The following is a description of a gene set: from publication Chen X, Barozzi I, Termanini A, Prosperini E, Recchiuti A, Dalli J, Mietton F, Matteoli G, Hiebert S, Natoli G (PMID 22802645) Human Gene Set: GSE33162_HDAC3_KO_VS_HDAC3_KO_MACROPHAGE_DN Genes down-regulated in macrophages with knockout of HDAC3: heterozygous versus homozygous. Pan-Hdac inhibitors (HDACi) are endowed with a potent anti-inflammatory activity, but the relative role of each of the eleven Hdac proteins sensitive to HDACi to the inflammatory gene expression program is unknown. Using an integrated genomic approach we found that Hdac3-deficient macrophages are unable to activate almost half of the inflammatory gene expression program when stimulated with lipopolysaccharide (LPS). A large part of the activation defect is due to loss of basal and LPS-inducible expression of IFNb, which in basal cells maintains Stat1 protein levels, and after stimulation acts in an autocrine/paracrine manner to promote a secondary wave of Stat1-dependent gene expression. We show that loss of Hdac3-mediated repression of nuclear receptors leads to hyperacetylation of thousands of genomic sites and associated gene derepression. The upregulation of the constitutively expressed prostaglandin endoperoxide synthase, Ptgs1 (Cox-1), has a causative role in the phenotype, since its chemical inhibition reverts the Ifnb activation defect. These data may have relevance for the use of selective Hdac inhibitors as anti-inflammatory agents. studied in species Homo sapiens, and this is the list of marker genes: RTRAF, SELENOT, PVT1, LAMTOR1, TSPAN31, ANXA2, VPS13C, ACTG2 (NCBI Gene Id 72), PLP2, PRPF39, SORL1, RUNX2, RIOK3, ADGRG3, DSTN, COMMD2, VMP1, LIG3, ENTPD4, SLC66A3, TRAM1, ST3GAL6, KLF6, SDCBP, MICOS10, GGH, PTGR3, RABGEF1, MAST2, PGK1, RWDD1 (NCBI Gene Id 82733), UGGT2, ADAM19 (ADAM metallopeptidase domain 19), SEMA4B, KLHDC2, CAB39, EOMES, ANP32B, S100A6, ZFP36L2, THTPA, PRDX4, MDFIC, WTAP, SERPINB6, PUS10, USP3, S100A4, TCF19, IER3, SH3GLB1, KIF4A, PRR13, ZFR, ARPC5 (actin related protein 2/3 complex subunit 5), EN2, TMEM163, PLEKHF2, ARPC2, RPA1, EIF2S3, CFL1, CFAP97 (cilia and flagella associated protein 97), ITGAX, ATP2A3, LIN7C, IDH3A, RORA, GABARAP, YBX3, ANXA1, FBLN7, TMEM30A, MTA1, DNMT3A, SH2D1A, HNRNPD, PDCD10, YWHAE, MRPL33, GZMB, CDKN1B, ELOC, PLEKHB2, PFKFB1, GNB1, ACTG1, ZNF207 (NCBI Gene Id 7756), GSR, VIM, DOCK2, LGALS3, CKS1B, MMADHC, TMEM98, NIBAN1, CALCB, ARL5A, ZMPSTE24, IFNG, ARF6, NUDT21, LPIN1, MYL9, C3orf38, TPM3, SMC2, QRICH1, GABARAPL1, FIGNL1, NUDT4, GNG10 (G protein subunit gamma 10), TMED7 (transmembrane p24 trafficking protein 7), PLTP, MKI67 (NCBI Gene Id 4288), ATG12, PCBP2, SMNDC1, WDHD1, ANP32E, ATP5PF, PCLAF, PSMD14, SNAPC3, HYOU1, DNM1L, MID1IP1, ACTB, CTLA4, C6orf89, ZEB2, MYO9B, BHLHE40, GNAI3, H1-2, CASP1, B4GALT7, CCR2, STX7, GMNN, CENPE, TRAT1, HIF1A, MICAL1, AKR1A1, PHF23, S100A11, IL1RL1, GSK3B, VAPA (NCBI Gene Id 9218), MAD2L1, YIPF4, PPIA, TCAF2, HMGB1, NCAPG2, CDCA3, ZCCHC9, RRM2, GBX2, IL18R1, RHOQ, CANX, HMGB2, AP1S2, POLE, BTG2, CHMP5, WWP1, ARL4D, CRKL, HNRNPA3, CNIH1, TAB2, CCNT2, ZSCAN26, PTGES3 (NCBI Gene Id 10728), PRDM1, PTPRC, ANXA4, DEK, ABRACL, ITGA4, RHPN2, TACSTD2, C1R, SNX6, AIDA, AK3, USP1, TRAPPC1, SEM1, RNF146, PTGER4, STMN1, ABHD10, MMD, BCKDHB, STK26, BCL2A1